Given this list of marker genes ARHGAP31, ACP3, POLD3, TP53BP1, BCAS1, KLHDC2, XRCC3, IL4, GSS, MLH1, SLC7A6, ADAM12, DAAM1, CNPY4, CPE, MTRES1, SAG, CMC2, KDM5C, PPFIBP1, CDKL4, WDHD1, LHFPL4, ERLEC1, GPR171 (NCBI Gene Id 29909), PLD2, CDC7, NBAS, HAUS8, PHACTR4, CCDC30, TSN, TM7SF2, LRP8, KIF2A, MFSD11, BCAS3, TSPAN5, PCYOX1, RASGRP3, TUBE1, ABCA3, CTNNA1 (NCBI Gene Id 619480), PLEKHF1, NLRX1, DTYMK, EPAS1, SPSB1, TMEM63A, ZBTB43, GDPD5, LYPD6B, DRC12, SPRED1, SRGAP3, KIAA1191, CCDC93, SLC12A7, SSTR5, CACFD1, PARN, C19orf47, ASIC3, FURIN, GGA2, HIC1, ITGB3, DAW1, B3GLCT, RAB3A, GAREM1, ENTPD4, ACSS2, ADAMTSL3, SLC30A9, AR, TIMELESS, COL17A1, PHF7, SLC35D2, TMCC3, BEND3, HDHD2, GRN, GFM1, NR1H4, MRPL44, C3, ABTB3, SLC38A10, POLR1C, CSNK1D, DLG1, POLR3E, LRR1, GPN1, MTMR4, CSPG5, TATDN1, AHR, PDZRN3, C19orf33, FOXP3, SYCP2L, CHST11, MYOF, WDR11, ITGAX, CMKLR1, CCDC198, E2F3 (E2F transcription factor 3), COMTD1, MBOAT1, SIN3B, ZFAND1, DHX33, WDR7, RMDN3, ZNF569, UBE2E2, TMEFF2, FOXN3, SLC25A14, CDH3, DSCC1, PREB, PTGR2, GMEB1, FFAR2, MATN2, ABHD16A, EXTL2, SHLD1, MFSD6, RBM14, UNG, LRIG3, WDR4, CCNE1, CCL20, TTC27, POLR1G, RNF144A, AASDH, TMEM170B, MTX3, FAP, LRPAP1, NBR1, PFAS, SLC25A15 (solute carrier family 25 member 15), PDLIM4, AHRR, FAM20A, TOR1B, EHD1, GJA1, CCDC28A, MTMR9, TNFAIP1, IL17A, HGSNAT, CDYL2, SNHG10, DNMT3B, RAP2C, GPATCH1, TBC1D31, ATP10A, PMVK, SHTN1, NEK3, FAAP20, DSP, CDK6, ZDHHC14, SGK3, KRT72, SKP2, CCSER1, ZNF385B, CELF4, JAK2, CNGA1, CEP128, L2HGDH, TSPAN2, POLD1, DOP1B, DBP, SEMA4A, IL21, TESC, SYCE2, ACER3, PTGER3, PINK1, KLHDC10, AMPH, ABRAXAS2, here is a description of the gene set: from publication Peltier DC, Simms A, Farmer JR, Miller DJ (PMID 20483728) Genes up-regulated in the mature neuron cell line: control versus infected with western equine encephalitis virus. studied in species Homo sapiens Human Gene Set: GSE16451_CTRL_VS_WEST_EQUINE_ENC_VIRUS_MATURE_NEURON_CELL_LINE_UP Human neuronal differentiation alters responsiveness to innate immune stimuli and virus infections. We used microarrays to examine the transcriptional responses of the human BE(2)-C neuroblastoma cell line to infection with western equine encephalitis virus (WEEV).